Given this list of marker genes SLC25A37, LMBR1 (NCBI Gene Id 85501), CCDC7, LRG1, ERO1B, LINC00622, SMAD4, CEP85, ZNF200, ATF3, ZNF831, GNG11, PELI2, MKLN1, RAI2, AQP11, ZNF253, EIF3A, ATP8A1, POLE, MAP1LC3B, HK2, TAS1R1, TBC1D19, PAMR1, GOLGA4, CPVL-AS2, SKIC3, SRL, PCOLCE, HEPH, ZSCAN18, CTNNAL1, MYLK4, ZNF668, DLGAP4, JPH1, SLC25A20, BLMH, CDAN1, DTWD1, ZNF45, SMAP2, LRATD1, PTEN, CSRNP1, SMAD2, SLC30A9, PLEKHO1, MAGEC2, VIPAS39, KIAA0930, ARCN1, FERMT3 (NCBI Gene Id 83706), FRY, ZSWIM5, TRIM16, HAPSTR1, KCP, IKBKB, RFC3, FCRLA, VXN, SEPHS2, FENDRR, PDGFC, BRPF3, XYLT1, TRAF4, ABCB4 (ATP binding cassette subfamily B member 4), SPATA4, ZNF44 (zinc finger protein 44), DPY19L4, PPFIA1, EPCAM, RNF8, LPXN, FBXO11, FCMR, MAP3K20, NCBP3, KTI12, ZFHX4, SCP2D1, CXCL8, ZNF614, NEDD1, PADI1, NFE2L2, PDE4D, LINC00342, CLDN16, MED24, STXBP5, NOTCH1, CTAGE1, CLK4, ISM2, TMEM259, SMG6, CCNYL1 (cyclin Y like 1), IL19, CALHM5, ZBTB6, PRRG1, AATK, DGKI (diacylglycerol kinase iota), MYO1B, DNAJB4, MIR646HG, TIPARP, SPTLC1, MAFF, SPIN4, PI3, ZNF571, SECTM1, COL6A3, DUSP4, RNF24, TFE3, DGKH, ZNF624, ZNF747, INPP4A, ARMC2, CFP, STK24, C17orf78, BIN1, USP37, FAF2, TBC1D25, AHRR, SHC1, EVPL, CRNKL1, TPST2, ILF2, CALCA, SLC7A10, ZNF225, ZNF273, LACC1, UHMK1, C5orf47, GYG2, SFT2D3, C3orf36, DONSON, CTNNA3, CXXC1P1 (NCBI Gene Id 392459), TIRAP, METTL4, TNIK (TRAF2 and NCK interacting kinase), THBS1, KCNK2, DESI2, MCF2, GSTCD, HAUS6, VEGFA, HOOK3, CATSPER2, SERPINA7, SPRR3, PTGER2, RCAN3, BCR, IL20RB, CYP1B1, TJP2, HDAC1, DLGAP5, CYP4B1, CD96, POLB, PITPNM2, TTLL6 (NCBI Gene Id 284076), TXLNB, MAMSTR, PEX12, IQCE (NCBI Gene Id 54774), SERINC1, FAM3C, SLC9A9, SEC62, ZFAND5, PPP6R3, ZNF700, ENG, KLK12, ADPRM, ABHD12, here is a description of the gene set: from publication Lawrence BP, Denison MS, Novak H, Vorderstrasse BA, Harrer N, Neruda W, Reichel C, Woisetschläger M (PMID 18270326) VAF347 is a low molecular weight compound which inhibits allergic lung inflammation in vivo. This effect is likely due to a block of dendritic cell (DC) function to generate pro-inflammatory T-helper (Th) cells since VAF347 inhibits IL-6, CD86 and HLA-DR expression by human monocyte derived DC, three relevant molecules for Th-cell generation. Here we demonstrate that VAF347 interacts with the aryl hydrocarbon receptor (AhR) protein resulting in activation of the AhR signaling pathway. Functional AhR is responsible for the biological activity of VAF347 since, i) other AhR agonists display an identical activity profile in vitro, ii) gene silencing of wild type AhR expression or forced over-expression of a trans-dominant negative AhR ablates VAF347 activity to inhibit cytokine induced IL-6 expression in a human monocytic cell line and iii) AhR deficient mice are resistant to the compound’s ability to block allergic lung inflammation in vivo. These data identify the AhR protein as key molecular target of VAF347 and its essential role for mediating the anti-inflammatory effects of the compound in vitro and in vivo. species: Homo sapiens Human Gene Set: GSE10463_CD40L_AND_VA347_VS_CD40L_IN_DC_UP Genes up-regulated in comparison of dendritic cells activated in the absense of VAF347 versus those activated in the presence of VAF347.